Given this list of marker genes DUSP9, RHPN2, SPINT2, CACNA1H, PHLDA3, MT1F, FBXO17, RAB20, NBEA, SRP54, CCN4, BASP1, ASPH, FUT4, TMEM248, CSRNP1, TANC2, GPR89A, SEMA4G, SEC24D, FADS2, SSR3, ECHDC2, RHOB, SLC46A1, SEC61A1, TTC13, HM13, MBOAT2, PGAM2, ECI2, FNIP2, DUSP14, TSPAN15, ATP6V0C, TOP1MT, CRELD2, CFAP251, RRBP1, CDC42BPB, GORASP2, MT1X, BTG2, GPM6A, LPIN2, SLAMF9, FARP2 (FERM, ARH/RhoGEF and pleckstrin domain protein 2), EDEM1, ABCA1, DCAF12, TNFRSF17, GUSB, SEL1L, SLC1A3, RRP1B, TULP3, PIK3CB, GSTP1, STING1 (stimulator of interferon response cGAMP interactor 1), TRPT1, SLC12A8, IL6ST, CREB3L2, ANTXR1, CTSZ, ABCC1, RHOBTB3, SEC24A, SSR1, DERL1, CKAP4, YAP1, SPCS2, TSPAN31, SDC1, SPATS2, MPZL2, PEX11A, AMZ2 (NCBI Gene Id 51321), CCPG1, BHLHA15, MTDH, USP2, PAWR, ALDH7A1, OSBPL1A, HIVEP3, P4HB, SLC25A39, SYDE2, CCND2, PRRG4, IGF1R, ST14, UACA, ICA1, YIPF6, TXNDC11 (thioredoxin domain containing 11), PDIA3, PECR, EPDR1, CEBPB (NCBI Gene Id 90277), HNRNPLL, UBE2J1 (ubiquitin conjugating enzyme E2 J1), ERO1A, NRG2, KIAA1217, SRPRB, MAGED1, XBP1, PHLDA1, HSP90B1, B3GALNT1, TERT, GLS2, EPPK1, COQ3, INTU, HDLBP, MATN2, ADA, FKBP14, RAB3D, CORO2B, ANXA5, TST, CITED2, ITGB5 (NCBI Gene Id 3693), ENPP1, TENT5C, CERS6, NCKAP1, MAMDC2, IRF4, LAPTM4B, CPED1, PPA1, TACC2 (NCBI Gene Id 10579), OXR1, LARS1, PDIA4, CLVS1, TPST1, TMEM38B, TMED10, IRS2, TMED9, IFITM3, MCFD2, SH3BGRL2, SMOC1, SLC7A5, LARGE2, RBM47, ATP2B4, FAM135A, TP53INP1, TRIB1, MAN1B1, SSR2, SNAI2, CLPTM1L, MANSC1, NSD3, PLA2G12A, SPAG6, MALAT1, SHROOM3, EPCAM, TG, KCNN4, TMEM150A, TMED1, NEGR1, SKIL, DUSP22, PYCR1, SELPLG, NOMO1, DUSP16, CLTB, HID1, AIG1 (androgen induced 1), WFS1, CRLF1, BBS2, BBS7, PRICKLE1, PPEF2, WIPI1, CHRND, EVC2, CD2BP2, FOXP2, KDELR1, C15orf39, RPN1, TGM2 (NCBI Gene Id 7052), GABRA4, ENTPD1, RGS3 (NCBI Gene Id 5998), FNDC3B, ELL2, BTG3, FABP5, GGTA1, CCNG1, PIWIL4, STARD5, TSPAN13, PVR, CYSTM1, PON2, CDV3, FADS3, BMP8B, CHST11, RHOBTB1, AGPAT5, BEX3, MFSD4A, CACNB3, LMAN1, ATOSA, FKBP11, DSP, SYNE4, LAX1, HIPK1, TPST2, DYNLL2, ARMCX3, ANKRD6, FILIP1, PLEKHF1, SRP68, EXTL2, PDIA6, ABCB1, TJP1, SPINT1, IRF6, PRDM1, MANF, MYO1D, EAF2, RAB2A, MGARP, NUDT4, PRAF2, SPCS1, CDK18, CHID1, RABGGTA, ARMCX2, EYA4, FAXC, SMPDL3B, KDELR2, LEPROTL1, DLL3, SLC16A6, CNPY2, BLNK, DENND5B, SLC38A10, SELENOM, SURF4, SLC25A33, ZNF25, CD44, EDEM2, NARS1, NFIL3, STT3A, MYOM1, RASIP1, SDC3, ERGIC1, ASNS (NCBI Gene Id 440), UNC13B, CPEB3, DCLRE1B, LAPTM4A, UCK2, REXO2, here is a description of the gene set: from publication Pasqualucci L, Bhagat G, Jankovic M, Compagno M, Smith P, Muramatsu M, Honjo T, Morse HC 3rd, Nussenzweig MC, Dalla-Favera R (PMID 18066064) studied in species Mus musculus Genes up-regulated in post-GC, BCL6 dependent B cell non-Hodgkin's lymphoma (B-NHL) vs MYC driven pre-GC lymphoma. Most human B cell non-Hodgkin's lymphomas (B-NHLs) derive from germinal centers (GCs), the structure in which B cells undergo somatic hypermutation (SHM) and class switch recombination (CSR) before being selected for high-affinity antibody production. The pathogenesis of B-NHL is associated with distinct genetic lesions, including chromosomal translocations and aberrant SHM, which arise from mistakes occurring during CSR and SHM. A direct link between these DNA remodeling events and GC lymphoma development, however, has not been demonstrated. Here we have crossed three mouse models of B cell lymphoma driven by oncogenes (Myc, Bcl6 and Myc/Bcl6; refs. 5,6) with mice lacking activation-induced cytidine deaminase (AID), the enzyme required for both CSR and SHM. We show that AID deficiency prevents Bcl6-dependent, GC-derived B-NHL, but has no impact on Myc-driven, pre-GC lymphomas. Accordingly, abrogation of AID is associated with the disappearance of CSR- and SHM-mediated structural alterations. These results show that AID is required for GC-derived lymphomagenesis, supporting the notion that errors in AID-mediated antigen-receptor gene modification processes are principal contributors to the pathogenesis of human B-NHL. Human Gene Set: PASQUALUCCI_LYMPHOMA_BY_GC_STAGE_UP